Given this list of marker genes mt-Nd6, Dld, Cox5b, mt-Co3, Bdnf, mt-Nd1, mt-Nd4, Cox7b, Cox7b2, Uqcrc2, Ndufc2, Cox5a, Uqcr11, Ndufb9, mt-Nd2, Cyc1, Cox8a, Uqcrh, Sdhb, Ndufv1, Ndufa7, Cox8b (cytochrome c oxidase subunit 8B), Ndufs6, Afg1l, Coq9, Uqcrc1, Ndufs2, Sdhc, mt-Nd5, Ndufs3, Ndufb6, Sdhd, mt-Nd3, Cyct, Ndufa10, Cox7c (NCBI Gene Id 12867), Uqcc3 (NCBI Gene Id 107197), Cox4i2, Dnajc15, Ndufs7, mt-Cytb, Uqcr10, Ndufv2, Cox4i1, Ndufaf1, Uqcrfs1 (NCBI Gene Id 66694), Uqcrq, Ndufs8, Cox7a2, Cox8c, Ndufb8, Iscu, Cycs, Sdha, Cox7a1, Cox6a1, Ndufa11, Park7, Cox7a2l, Ndufa8, Pink1, Cox6a2, Ndufs1, Uqcrb, Slc25a51, Sdhaf2, here is a description of the gene set: A process in which a series of electron carriers operate together to transfer electrons from donors such as NADH and FADH2 to oxygen to generate a transmembrane electrochemical gradient. studied in species Mus musculus Mouse Gene Set: GOBP_AEROBIC_ELECTRON_TRANSPORT_CHAIN